The following is a description of a gene set: species: Mus musculus Mouse Gene Set: GOBP_SARCOPLASMIC_RETICULUM_CALCIUM_ION_TRANSPORT The directed movement of calcium ions (Ca2+) into, out of or within the sarcoplasmic reticulum., and this is the list of marker genes: Pde4d, Ryr3, Gstm7, Casq1, Chd7, Trdn, Ryr2, Sln, Hrc, Dmd, Atp2a2, Calm2, Strit1, Atp2a1, Camk2d, Casq2, Zmpste24, Cacng1, Nol3, Dhrs7c, Ccl3, Cacna1c, Fkbp1b, Calm3, Calm1, Ryr1, Pln, Ank2, Gsto1, Ccr5, Tmem38b, Tmem38a, Mettl21c, Mrln, Slc8a1